The following is a description of a gene set: Human Gene Set: REACTOME_RETROGRADE_NEUROTROPHIN_SIGNALLING Retrograde neurotrophin signalling species: Homo sapiens, and this is the list of marker genes: DNM3, AP2B1, DNAL4, AP2A1, DNM1, CLTC, AP2A2, AP2M1, DNM2, NGF, NTRK1, CLTA, SH3GL2, AP2S1